The following is a description of a gene set: Mouse Gene Set: GOMF_CYSTEINE_TYPE_ENDOPEPTIDASE_INHIBITOR_ACTIVITY Binds to and stops, prevents or reduces the activity of a cysteine-type endopeptidase. species: Mus musculus, and this is the list of marker genes: Stfa2l1, Csta3, Csta1, Serpinb3b, Ahsg, Cst5, Cstdc3, Spock1, Cst13, Cast, Cstdc4, Ctla2b, Cstb, Xiap, Snca, Kng2, Kng1 (kininogen 1), Fetub, Birc6, Cst7, Stfa3, Naip1, Serpinb3c, Birc7, Cst3, Ngp, Serpinb3a, Cstdc5, Cstdc6, Cst11, Wfdc2, Ltf, Cst12, Cstdc1, Arrb1, Stfa1, Cst9, Hrg, Stfa2, Csta2, Csn2, Serpinb3d, Serpinb13, Cstl1, Serpina3g, Pttg1, Birc5, Cst8